Given this list of marker genes GAB1, NRG3, ERBB2, GRB2, NRG1, HBEGF, EREG, ERBB4, EGF, BTC, PIK3R1, PIK3CA, ERBB3, NRG2, EGFR, NRG4, here is a description of the gene set: Reactome Pathway: PI3K events in ERBB2 signaling species: Homo sapiens ERBB2:ERBB3 and ERBB2:ERBB4cyt1 heterodimers activate PI3K signaling by direct binding of PI3K regulatory subunit p85 to phosphorylated tyrosine residues in the C-tail of ERBB3 (Y1054, Y1197, Y1222, Y1224, Y1276 and Y1289) and ERBB4 CYT1 isoforms (Y1056 in JM-A CYT1 isoform and Y1046 in JM-B CYT1 isoform). Regulatory subunit p85 subsequently recruits catalytic subunit p110 of PI3K, resulting in the formation of active PI3K, conversion of PIP2 to PIP3, and PIP3-mediated activation of AKT signaling. Heterodimers of ERBB2 and EGFR recruit PI3K indirectly, through GRB2:GAB1 complex, which again leads to PIP3-mediated activation of AKT signaling. part of: Signaling by ERBB2